Given this list of marker genes IDO1, HAAO, KYNU (NCBI Gene Id 8942), KMO (NCBI Gene Id 8564), ACMSD (aminocarboxymuconate semialdehyde decarboxylase), here is a description of the gene set: The chemical reactions and pathways resulting in the formation of quinolinate, the anion of quinolinic acid, also known as 2,3-pyridinedicarboxylic acid. Human Gene Set: GOBP_QUINOLINATE_BIOSYNTHETIC_PROCESS species: Homo sapiens